Given this list of marker genes Usp18 (ubiquitin specific peptidase 18), Cotl1, Col1a2, 6330403L08Rik, Ch25h, Ptpn14, Gsta1, Phldb2, Gpha2, Elavl2, Ppp1r3c, Mme, Zfp704, Tsc22d1, Htr1b, Cntn1, Tmem255a, Clec11a, Cnn2, Mob3b, Dab1, Hsd17b13, Hoxaas2, Gpm6b, Ppp2r3a, Stbd1, Mei4, Vav3, Igfbp3, Smarca1, Dmpk, C2, Ar, Limch1, Loxl1, Dpy19l1, Nptx1, Vwa1, Pcdhb12, Fkbp10, Atp6v1c2, Igdcc4, Syt9, Calhm5, Gfra2, Palld, Stag3, Prkd1, Il2rg, Trdc, Slc14a1, Lrrn3, Cpe, Lrp4, Rtn2, Ptger4, Cpeb1, Atp8a1, Kctd4, Sardh, Gdnf (NCBI Gene Id 14573), Nrxn3, 2410022M11Rik, Cacnb4, Rasa3, Cxcl12, Nrcam, Rspo3, Klhl10 (NCBI Gene Id 66720), Nexn, Gna14, Samd12, Flrt2, Efemp2, Chic1, Dlx4os, Rhobtb3 (Rho-related BTB domain containing 3), Zfp36l1, Ankrd6, Gprasp2, Crispld2, Svip (NCBI Gene Id 75744), Chsy3, Sipa1l3, Irf4, 2310015A10Rik, Gbp7, Guca2a, Minar2, Syne1, Slc39a10, Tnfrsf11b, Sh3kbp1, Pfn2, Arsi, Tlcd4, Gpat3, Smim22, Myl9, Rsad1, Slc38a4, Gm21992, Dnajc6, Tcea3, Fcgbp, Car8, Tgfb2, Plat, Bcl2l15, Tuba8, Tafa5, Tslp, Fggy, Plcxd2, 2810002D19Rik, 4930550C14Rik, Sox21, Pdlim3, Myef2, Igfbp5, Jazf1, Pla2g4a (phospholipase A2, group IVA (cytosolic, calcium-dependent)), Pdzrn4, Zscan18, S100a3, Pkia, Sorcs3, Gm5113, Thbs2, Fkbp14, Amy1, S100a4, here is a description of the gene set: species: Mus musculus Mouse Gene Set: CHEBOTAEV_GR_TARGETS_DN Glucocorticoids are potent inhibitors of mouse skin tumorigenesis. The glucocorticoid control of cellular functions is mediated via the glucocorticoid receptor (GR), a well-known transcription factor. Recently, we generated transgenic mice overexpressing GR under control of the keratin5 (K5) promoter, and showed that K5.GR animals are resistant to skin carcinogenesis. Follicular epithelial stem cells (SCs), located in the bulge region of the hair follicle, are believed to be one of the target cells for skin carcinogenesis. We found that the number of putative hair follicle SC detected as label-retaining cells was significantly less in the K5.GR transgenics compared to wild type (w.t.) littermates. We also showed that GR overexpression led to a reduction in the clonogenicity of the follicular epithelial SCs. We evaluated the global effect of GR on gene expression in a population of follicular SC-enriched bulge keratinocytes isolated by fluorescence activated cell sorting. We found that GR affected the expression of numerous bulge SC 'signature' genes, genes involved in the maintenance of SC and progenitor cells of non-epidermal origin and proapoptotic genes. Our findings underscore the important role of GR signaling in the homeostasis of follicular epithelial SCs, and suggest that the reduction in their number may underlie the tumor suppressor effect of GR in the skin. from publication Chebotaev D, Yemelyanov A, Zhu L, Lavker RM, Budunova I (PMID 17146443) Genes down-regulated in follicular epithelial stem cells after transgenic expression of GR under control of the keratin5 (K5) promoter.